The following is a description of a gene set: Reactome Pathway: The NLRP1 inflammasome NLRP1 is activated by MDP. The NLRP1 inflammasome was the first to be characterized. It was described as a complex containing NALP1, ASC, caspase-1 and caspase-5. Unlike NLRP3, NLRP1 has a C-terminal extension containing a CARD domain, which has been reported to interact directly with procaspase-1, obviating a requirement for ASC, though ASC was found to augment the interaction. Mouse NLRP1 has no PYD domain and would therefore not be expected to interact directly with procaspase-1. Like the NLRP3 inflammasome, K+ efflux appears to be essential for caspase-1 activation. Ribonucleoside triphosphates (NTPs) are required for NALP1-mediated caspase-1 activation with ATP being the most efficient, Mg2+ was also required. The human NLRP1 gene has 3 paralogues in mouse that are highly polymorphic. Differences between mouse strains underlie susceptibility to anthrax lethal toxin (Boyden & Dietrich 2006). studied in species Homo sapiens part of: Inflammasomes, and this is the list of marker genes: BCL2, BCL2L1, NLRP1